Given this list of marker genes ERCC2, TARS1, MARS1, AARS1, GTF2H5, ERCC3, GTF2E2, RNF113A, CARS1, MPLKIP, here is a description of the gene set: Tiger tail banding Human Gene Set: HP_TIGER_TAIL_BANDING An abnormal appearance of hair under polarizing microscopy (using crossed polarizers), whereby hair shafts show striking alternating bright and dark bands, often referred to as tiger tail banding. studied in species Homo sapiens